Given this list of marker genes Zfp608, Prnp, Zfp324, Cd24a, Frem1, Gpr101, Aurkb, Atp1b4, Mblac2, Scd1, Ppm1l, Crls1 (NCBI Gene Id 75371), Cpsf7, Steap2, Dsg3, Xpo1, Ptcd1, Zfp169, Rasl11a, Tmem167b, Recql4, Acsl1, Neu1, Srgap3, Snapin, Far2, Bcl2, Scpppq1, Syt1, Sall3, Acer1, Dpp4, Foxp2, Phf11, Gucy1a2, Pou3f2, Sgpp1, Rarres1, Fgf12, Usp16, Pum2, Cripto, Lrrc7, Vipas39, Esyt2, Adam22, Pitpna, Rnf169, H13, Crkl, Ddx6, Zbtb37 (zinc finger and BTB domain containing 37), Klf12, Mtif3, Top1, Fam89b, Ino80c, Iqsec3, Zc3h13, St6galnac5, Nap1l2, Rsl1, 2210408I21Rik (NCBI Gene Id 72371), Mei4 (meiotic double-stranded break formation protein 4), Nipsnap1, Mybl1, Idh3a, Zfp62, Mbnl1, Wapl, L1cam, Stx17, Pid1, Tfr2, Rmi1, Zdhhc16, Frrs1 (NCBI Gene Id 99552), Tom1l2, Mrps34, Cmip, Cx3cr1, Fer, Dgat2l6, here is a description of the gene set: Mouse Gene Set: MIR_216C_3P species: Mus musculus from publication Chen Y, Wang X (PMID 31504780) Genes predicted to be targets of miRBase v22 microRNA mmu_miR_216c_3p in miRDB v6.0 with MirTarget v4 prediction scores > 80 (high confidence targets).